Given this list of marker genes PSMA2, PSMD1, PLK1, PSMD12, UBB, PSMA5, PSMB4, PSMA6, SEM1, GTSE1, PSMA1, PSMD14, TUBAL3, CCNB2, PSMC1, TUBB2B, PSMC4, TUBB6, CCNB1, CDK1, PSMC6, PSMB3, PSMB5, PSMB1 (proteasome 20S subunit beta 1), HSP90AA1, FKBPL, TUBA1B, TUBB1, TUBA3C, PSMC5, TUBB4B, PSMC3, PSMD3 (NCBI Gene Id 94019), UBC, MAPRE1, PSMD13, HSP90AB1, TUBA1A, PSMD7, TUBB3, PSMA7, ADRM1, TUBB8B, TUBA8, PSMB7 (proteasome 20S subunit beta 7), PSMD8, TUBA3D, TUBA4A, PSMA4, TUBB8 (NCBI Gene Id 347688), PSMC2, TUBA3E, TUBA1C, PSMD6 (NCBI Gene Id 9861), TUBB2A (NCBI Gene Id 92919), PSMD11, PSMB2, RPS27A, UBA52, TUBB4A, CDKN1A, PSMB6, PSMD2, PSMA3, TUBA4B, TP53, here is a description of the gene set: Human Gene Set: REACTOME_THE_ROLE_OF_GTSE1_IN_G2_M_PROGRESSION_AFTER_G2_CHECKPOINT The role of GTSE1 in G2/M progression after G2 checkpoint species: Homo sapiens